Given this list of marker genes FGF20, MET, FGF5, PLCG1, ITPR2, FGF18, VEGFC, FGF3, HGF, FGF6, RET, GDNF, FLT1, PDGFC, PDGFRA, PDGFRB, PDGFB, VEGFA, FGF19, FGF22, FGF1, KDR, MST1R, FGF9, EGFR, FGF8, MST1, FGF4, FGF7, ERBB2, PLCG2, ERBB3, NTRK1, PDGFA (NCBI Gene Id 5154), PDGFD, FGF16, FGFR4, ITPR3, FGF23, VEGFD, NGF, FGF21, FGFR2, FGFR1, FGFR3, NTRK2, FGF10, VEGFB, FGF17, NTRK3, FLT4, ITPR1, EGF, ERBB4, FGF2, here is a description of the gene set: Pathway Definition from KEGG: GF -> RTK -> PLCG -> IP3 -> ITPR -> Ca2+(cyto) studied in species Homo sapiens Human Gene Set: KEGG_MEDICUS_REFERENCE_RTK_PLCG_ITPR_SIGNALING_PATHWAY RTK-PLCG-ITPR signaling pathway. Pathway ID: N01641. Pathway type: Reference. Pathway class: nt06528 Calcium signaling.